Given this list of marker genes Pum2, Dgcr8, Trub1, Ripk1, Zfp36, Fxr1, Trim71, Pum1, Ago2, Bmp4, Tial1, Fmr1, Tgfb1, here is a description of the gene set: Any process that increases the frequency, rate or extent of the inactivation of gene expression by a posttranscriptional mechanism. Mouse Gene Set: GOBP_POSITIVE_REGULATION_OF_POST_TRANSCRIPTIONAL_GENE_SILENCING studied in species Mus musculus